The following is a description of a gene set: Human Gene Set: HP_MEDIAN_CLEFT_PALATE Median cleft palate Cleft palate of the midline of the palate. studied in species Homo sapiens, and this is the list of marker genes: PROP1 (PROP paired-like homeobox 1), STAG2, EPG5, WNT5A, SLC2A10, FZD2 (NCBI Gene Id 2535), SIX3, ZSWIM6, FOXA2, PITX1, DVL1, PTCH1, LHX4, ATP6V1E1, TWIST1, CILK1, GLI2, TGIF1, FAM20C, OTX2, LBR, POU1F1, DVL3, NUAK2, HESX1, ALX3